The following is a description of a gene set: Mouse Gene Set: GOBP_DIPHOSPHATE_METABOLIC_PROCESS species: Mus musculus The chemical reactions and pathways involving diphosphate, the anion or salt of diphosphoric acid., and this is the list of marker genes: Sp7, Ank, Fgfr1, Enpp1, Ppa2